Given this list of marker genes Gm17882, Gm33450, 4930433E05Rik, Fbxl3 (NCBI Gene Id 50789), Slain1, Gm18075, Gm23459, 4933432I03Rik, Gm9298, Gm34907, Gm9290, Gm10076, Dach1, Gm9287, Gm49018, Gm25724, Rpl36a-ps1, Mzt1, Gm33525, Gm17366, Uchl3 (NCBI Gene Id 50933), Gm16260, Klf12, Gm23324, Gm36107, Gm7272, Gm15515, Gm4412, Gm24127, Gm26006, Gm9721, Gm25133, Gm22021, Gm24680, Gm25130, Gm9922, Gm18885, Tbc1d4, 4930432J09Rik, 1700128A07Rik, Rpl17-ps7 (NCBI Gene Id 674502), Prr30, Gm9247, Frg2f4, Pcdh9, Ednrb, Gm24345, Gm18148, Gm24280, 9330188P03Rik, Gm41231, Gm34589, D130009I18Rik, Mir5130, Rbm26, Slain1os, Ccdc202, Bora, Gm5207, Commd6, Kctd12, Gm23509, Gm18074, Gm34643, Gnb1-ps2, Gm17922, Gm5854, Gm23538 (NCBI Gene Id 115488388), Klf5, Pibf1 (NCBI Gene Id 75821), Klhl1, Pou4f1, 6330576A10Rik, Scel, Gm6145, Mycbp2 (NCBI Gene Id 97940), Gm7232 (predicted gene 7232), Gm16259, Gm25415 (predicted gene, 25415), Gm35909, Gm23437, 4930449E01Rik, Gm5671, Cln5, Gm24207, Gm4654, Gm25886, Gm18926, Ndfip2, Gm25495, Mir6390, Obi1, Gm18082, D130079A08Rik, Gm24770, Gm23276, Spry2, Dis3, Gm22970, Trim52, 5430440P10Rik, Gm23225, 4930517O19Rik, Gm6201, Gm49219, Gm34417, Gm22984, Gm33246, Gm46477, 4930474H20Rik, Hspd1-ps5, Gm25831, Lmo7, Gm19099 (NCBI Gene Id 100418249), Gm9302 (NCBI Gene Id 668683), Gm41230, C230086J09Rik, Gm5958, Gm4775, Gm24043, Acod1, here is a description of the gene set: Mouse Gene Set: chr14E2 species: Mus musculus